Given this list of marker genes TSC22D3, CUTA, TNNC1, GMPPB, IL11RA (NCBI Gene Id 3590), PRDM4, NNAT, LYRM1 (NCBI Gene Id 57149), PITX2, GPC3, IRX3, BDNF, KCNC2, RAB30, ARFGEF1, GRB7, PDS5A, FFAR2, HECTD1, NRF1, BACH1, FAM20B, SPEG, ENKD1, FOXA1, AAMDC, TLX3, DDAH2, DCX, CTNND1, PRPF38B, PLXNA3, LRMDA, ZEB2, GPRC5C, TLCD1, LTBP1, NTRK3, FBRS, MAPRE3, MINK1, ADRA1A, UBA1, HPCAL1, FLOT2, TSPAN7, GRHL3, BMP4, ARHGAP5 (NCBI Gene Id 394), RGS8, ZKSCAN7, VEZF1, TRIM62, EPC1, ETV1, GNAQ, PCDHB4, YWHAG, PTCRA, SLC25A35, MRFAP1, DEF6, RTP1, PAK5, NBEAL1, SLC25A28, DHH, TBC1D5, RCOR2, PHPT1, COX8C, TRMT1, DYRK2, RSF1, HIF1A, NEK8 (NCBI Gene Id 284086), DDR1, SLC25A14, CAMKV, NR2F1, UPK2, PPFIA2, KCNQ1DN, FKBP2, NDUFAF3, PTCHD1, ZNF385A, ARHGAP26, CPNE1, C1QTNF5, JUNB, IER5L, NHS, HSPA1A, CDC42EP3, TBX2, RPL41, FAM170A, SCUBE3, KAT5, SLC9A1, FGF9, PATL1, DNAJB1, BCL11B, GSK3B, XPNPEP1, KCNH2, NISCH, TUFT1, RASSF1, CORO6, QRFP, NACC1, KCTD15, MACROD2, TMEM47, CS, KIF1C, DSCAM (DS cell adhesion molecule), MAPK3, FRMD3, TRERF1, MEA1, PPP2R5C, ATP10D, ACTN1, PAPPA, MMP11, PKN1, GLTP, ZNF367, DUSP6, CRK, CRYBG2, KIF5A, RNF207, TSC22D1, NOL4, RD3, FEV, CAMK2G, KIFAP3, GNB3 (NCBI Gene Id 2784), CHMP4B, EFNA3, FOXP2, CCDC177, LHX2, CHD4, LSM12, HOXB6 (homeobox B6), SLC26A9, ZNF532, MAST2, KCNE3, MOGAT2, MORF4L2, LYN, CPLX2, SRMS, CALD1, LIPT2-AS1, ARMCX4, SHB, IL1RAPL1, MIDEAS, DSC2 (desmocollin 2), ODC1, KLHDC3, RYR1, H3-3B, ARX, TSHZ2, HCFC1, ZNF767P, KBTBD12, TLN1, TGFBR2, HBEGF, PRKACA, NRXN3, TPPP3, WNT10B, ARL6IP6, MNT, AIFM3, RAB5IF, STARD13, SCAMP5, CAP1, RHBDF1, FLI1, RHBDL1, SLC2A9, PTHLH, ADNP, PLEKHN1, TRIM8, MDK, HSPA1L, ANKRD13B, STAC2, CLDN4, PODN, GSX1, CILP2, CELF6, NFATC4, LDB2, CAPN6, PAX2, BEX3, ATXN7L2, TRPV2, ESYT1, PPP4R3B, MAB21L3, PPP1R16B, CDK14, PRKCH, ZSWIM8, MACO1, PPP1R9B, TFCP2L1, AQP6, BRWD3, DCUN1D3, RNF121, NR1D1, STIP1, FOXL2, MID2, RAB10, DALRD3, TXNDC17, CNTN6, RTN1, TRAF4, PRKAG1 (NCBI Gene Id 5571), CREB1, DBNDD2, DDIT4, GABARAP, ZC3H10, NRIP2, LZTS2, ALDH3B1, CA9, TMEM164, RBBP6, EPN3, MRPL14, CITED1, here is a description of the gene set: species: Homo sapiens Genes having at least one occurrence of the motif GCTGGNTNGNNCYNG in the regions spanning 4 kb centered on their transcription starting sites. This matches the TFCP2 transcription factor binding site V$CP2_02 (v7.4 TRANSFAC). Human Gene Set: CP2_02